Given this list of marker genes Csde1, Igf2bp3, Hnrnpu, Pabpc1, Dhx9, Ybx1, Paip1, Igf2bp1, Hnrnpd, Igf2bp2, Syncrip, here is a description of the gene set: An mRNA stabilization process in which one or more RNA-binding proteins associate with a sequence in the open reading frame called the coding region instability determinant (CRD). Mouse Gene Set: GOBP_CRD_MEDIATED_MRNA_STABILIZATION studied in species Mus musculus